Given this list of marker genes CDKN3, SCN1A, CHGA, URAD, AKAP12, HEBP1, LACTBL1, HABP4, EMILIN3 (elastin microfibril interfacer 3), MS4A2, MYOZ3, ZRANB3, SPMIP5 (NCBI Gene Id 143379), MUCL3, TAL1, S100B, POLG, AVIL, PEAR1, SLITRK4, ARHGAP36, EML3, OSBPL10, LY6H, ABCA1, HBEGF, ANAPC11, TSEN34, PDE3A, CLIC1, CHL1, SLC25A53, HHATL, SDHAF4, MRC2, SERPINA12, TYW1, TUBAL3, PRR15L, FAM162B, DPY19L2, SLURP2, SLC25A18, MYADML2, MAN2A2, NRTN, LEPROT, ILDR2, H1-1, FMNL3, AQP1, COL5A3, PPM1M, IFI30, CUL9, CAPS2 (calcyphosine 2), AFAP1, PACSIN1, TSC22D1, NR1I3, JHY (junctional cadherin complex regulator), MIR505, BCL7A, PRICKLE1, SDK2 (NCBI Gene Id 54549), GSX1, PJVK, GPR20, PODXL2, RNF122, CAVIN4, TMEM14A, HERPUD1, MICAL1, CENPA, CCNG2, CTDSP2, KCTD15, GJB3, CCS, TNNI1, KIZ, ACVR1B (activin A receptor type 1B), NKX1-1, KRT28, PIEZO2, ARL14, HK1, SLC23A2, CORT, CHDH, TMEM270, GUCY1B1, PNPLA7, ZNF394, STX2, ORC1, CDPF1, UQCC4, RNF180, SGMS1, INPP5A, CLCNKB, GAS6, LRRC9, IGFN1, CENPB, ITM2B, ATP8B1, IGSF3, ANK1, ANKRD34B, KCNT1, TFEC, SDC1, TBCEL, TBX1, TAS1R3, ARHGEF4, HSD17B11, TULP1, TMEM121B, MIR146B, ACVR1, TIMP1, CHST15, DTNA, WFDC3, WNT10B, KIF17, RTL6, TIFA, MIRLET7E, ALDH1A1, COQ9, ARRDC3, ABCD4, DGKD, PDC, PMM1, LHFPL5, LENG9, MIR187, GLCCI1, COPS9, ARHGAP45, IDE, MMP21, HOXA11, GDF10, CPA4, LMAN1L (NCBI Gene Id 79748), TLN1, CXCR1, NKX2-3, RNF220, TH, SHH, PLCG1, LRRK2, FBLN5, CYP2E1, STAB1, here is a description of the gene set: Genes down-regulated in CD4 T conv: control versus over-expression of SATB1 and FOXP3. Human Gene Set: GSE40274_CTRL_VS_FOXP3_AND_SATB1_TRANSDUCED_ACTIVATED_CD4_TCELL_DN The transcription factor FoxP3 partakes dominantly in the specification and function of FoxP3+ CD4+ T regulatory cells (Tregs), but is neither strictly necessary nor sufficient to determine the characteristic Treg transcriptional signature. Computational network inference and experimental testing assessed the contribution of several other transcription factors (TFs). Enforced expression of Helios or Xbp1 elicited specific signatures, but Eos, Irf4, Satb1, Lef1 and Gata1 elicited exactly the same outcome, synergizing with FoxP3 to activate most of the Treg signature, including key TFs, and enhancing FoxP3 occupancy at its genomic targets. Conversely, the Treg signature was robust to inactivation of any single cofactor. A redundant genetic switch thus locks-in the Treg phenotype, a model which accounts for several aspects of Treg physiology, differentiation and stability. species: Homo sapiens from publication Fu W, Ergun A, Lu T, Hill JA, Haxhinasto S, Fassett MS, Gazit R, Adoro S, Glimcher L, Chan S, Kastner P, Rossi D, Collins JJ, Mathis D, Benoist C (PMID 22961053)